The following is a description of a gene set: Mouse Gene Set: GOMF_AP_2_ADAPTOR_COMPLEX_BINDING studied in species Mus musculus Binding to an AP-2 adaptor complex. The AP-2 adaptor complex is a heterotetrameric AP-type membrane coat adaptor complex that consists of alpha, beta2, mu2 and sigma2 subunits and links clathrin to the membrane surface of a vesicle. In at least humans, the AP-2 complex can be heterogeneric due to the existence of multiple subunit isoforms encoded by different alpha genes (alphaA and alphaC)., and this is the list of marker genes: Hip1, Gabrb3, Sidt2, Tbc1d5, Bmp2k, Lmbrd1, Fcho1, Ldlrap1, Arrb1, Dab2, Aak1, Otof